Given this list of marker genes CDK5RAP3, MAP3K7, XBP1, SUMO1P1, PTPRN, TANK, MDM2, RPS27A, APBB1, ERLIN2, H2BC9, IKBKG, SMAD7, ELOB, AUP1, DTX3L, POLR2A, UBC, SMAD2, RALB, CAMLG, PACRG, HAPSTR1, UBB, CASP10, DAZAP2, MAGEA2, WFS1, RB1, BAG6, CRK, RPA2, RPL11, USP25, BAG2, ARIH1, MAGEC2, MAP1LC3A, FZD5, PCBP2, DDRGK1, BAG1, ARRDC1, TLR3, RNF20, CEBPB, DNAJB2, YOD1, MAGEA2B, PA2G4, TRIM28, NFE2L2, YWHAE, GSK3B, GPI, XRCC5, UBOX5, CHEK2, ATP6V0C, MOAP1, MFHAS1, SMG5, DET1, CKB, NDUFS2, STX8, SUMO2, PRKAR2A, SMAD3, PRKAR1A, RAD18, USP13, TRIP4, PRDX6, TUBB, SQSTM1, DLG3, PIAS2, SPART, HSP90AA1, GLMN (glomulin, FKBP associated protein), TXNIP, PTPN22, UQCRC1, BLZF1, FBXO7 (NCBI Gene Id 25793), SUMO3, MYOD1, CUL7, WRAP53, GABARAPL2, SUMO4, AICDA, NKD2, OTUB1, TRAF4, TMBIM6, FZD8, TUBA1B, TSG101, SNX9, SMAD1, FZD6, DBT, HERC2, GGN, HSPA8, HIF1A, PARP9, VCP, CCDC50, EGR2, YWHAZ, PRKACB, RRAGA (Ras related GTP binding A), SCN5A, RNF8, CCT2 (NCBI Gene Id 10576), PRKACA, NLK, SMAD6, CUL4B, PRKN, TRAF3, FATE1, MC1R, PIAS4, CACUL1, CALR, RELA, RTN4, CUL9, HGS, PDLIM2, UBASH3B, UBE2T, RNF40, HSPBP1, HSPA9, TNFRSF1B, RIPK1, PRR5L, CUL5, UBE2A, BCL2, PRR7 (NCBI Gene Id 80758), SMC6, KCNH2, PSMD1, PML, ACVR1B, TP53, CUL2, BAG4, PAX6, CUL4A, BECN1, GPR37, HSPA1L (heat shock protein family A (Hsp70) member 1 like), DTX1, PRKAR2B, SLF1, KCNQ1, TRIB2, ANAPC2, RIGI, BRCA1, PER1, SPOPL, KDM4A, SKI, ERBB3, ACTG1, AURKA, STING1, CBS, POU5F1, RNF34, MFN2, UBE2J1, GABARAPL1, PINK1, EGFR, JAK1, SUMO1, TRAF1, RBX1, HSPA1A, DNM1L, WBP1L, FHIT, FBXW7, NFKBIA, TRAF5, BOK, AXIN2, DAXX, CASP8 (caspase 8), RPL5, RPL23, USP2, MYC, DIO2, UBE2K, SPOP, TRIB3, MID1, UBE2N, TRAF2, CTNNB1, AMBRA1, AXIN1, RFFL, MUL1, ZNF675, HLTF, TNK2, RNF31, FAF1, PYHIN1, MC4R, TRIOBP, CACYBP, ASB4, STAT2, NAE1, GABARAP, GABARAPL3, HAPSTR2, PER3, TRIM37, UBXN7, RNF186, UBE2B, LRPPRC, STAT1, FOXO1, TCP1, VCL, CXCR4, HM13, PPARGC1A, UBE2C, UBE2L3, CUL1, DNAJA1, NGFR, SMAD5, UCHL1, ERLIN1, GRIK2, IKBKE, CASC3, ITCH, PARP1, SYT11, FANCL, CDKN1A, SH3KBP1, PATZ1, UBE2J2, JUN, CDKN1B, RANGAP1, ABI2, ENSG00000274276, HSP90AB1, HDAC6, FZD4, ARRB1, LIMK1, ARRB2, BCL10, CLU, HSPA5, NPLOC4, RALA, FAF2, RHOBTB3, STUB1, EIF4E2, WASHC1 (NCBI Gene Id 727741), ISG15, SHPRH (SNF2 histone linker PHD RING helicase), TPI1, CCNB1 (NCBI Gene Id 891), DERL1, UBA52, ABCB1, ANKRA2, SCAMP3, SLC25A5, MAP1LC3C (microtubule associated protein 1 light chain 3 gamma), HSPD1, CD40, HSPA1B, JKAMP, LAPTM5, FAU, SLF2, BAG5, NEK6, STAM, TOLLIP, APC, MAP1LC3B, TRIB1, NEDD8, BID, TGFBR1, SNCAIP, PSMA3, TNFRSF14, CUL3, SLC22A18, LTBR, MAP1LC3B2, ATXN3, UBXN1 (NCBI Gene Id 92151), UBE2G1, LYN, UBE2W, LAPTM4B, PIAS1, here is a description of the gene set: Human Gene Set: GOMF_UBIQUITIN_LIKE_PROTEIN_LIGASE_BINDING Binding to a ubiquitin-like protein ligase, such as ubiquitin-ligase. studied in species Homo sapiens